The following is a description of a gene set: Human Gene Set: WCAANNNYCAG_UNKNOWN from publication Xie X, Lu J, Kulbokas EJ, Golub TR, Mootha V, Lindblad-Toh K, Lander ES, Kellis M (PMID 15735639) species: Homo sapiens Genes having at least one occurrence of the highly conserved motif M152 WCAANNNYCAG in the regions spanning 4 kb centered on their transcription starting sites. The motif does not match any known transcription factor binding site. Comprehensive identification of all functional elements encoded in the human genome is a fundamental need in biomedical research. Here, we present a comparative analysis of the human, mouse, rat and dog genomes to create a systematic catalogue of common regulatory motifs in promoters and 3' untranslated regions (3' UTRs). The promoter analysis yields 174 candidate motifs, including most previously known transcription-factor binding sites and 105 new motifs. The 3'-UTR analysis yields 106 motifs likely to be involved in post-transcriptional regulation. Nearly one-half are associated with microRNAs (miRNAs), leading to the discovery of many new miRNA genes and their likely target genes. Our results suggest that previous estimates of the number of human miRNA genes were low, and that miRNAs regulate at least 20% of human genes. The overall results provide a systematic view of gene regulation in the human, which will be refined as additional mammalian genomes become available., and this is the list of marker genes: CACNB3 (NCBI Gene Id 784), SCNM1, STARD13, AP1G2, GDNF, CERT1, SLC25A28, SMAD5, ATXN7L2, HCFC1R1, VPS45, SP8, SALL1, CD244, SERTAD3, FOXM1, FOXP2, GBX2, CHTOP, PANK3, ELP6 (elongator acetyltransferase complex subunit 6), FBXO36, TMEM150A, CNOT4, CREB1, SCN8A, EPS8L2, NRAS, DMD, BMP4, CNGA1 (NCBI Gene Id 1259), TRMT10B, RAB3GAP2, TAFAZZIN, IFTAP, MACROD1, OTUD7B, RDH14, NFIX, LRRC74A, FGFR3, SLC38A9, SOBP, PHF12, LMAN2, ZNF32, WNT9A, AGXT2, PRRT2, ARF6, TRIM23, ZNF644, PCDH10, HAUS1, NUMA1, POLK, SUFU, FGFR1, PLCG1, NSG2 (neuronal vesicle trafficking associated 2), BTRC, CPNE9, KCNJ5, APH1A (aph-1 homolog A, gamma-secretase subunit), MIR22HG, NEUROD6, DNAJC18, MYH6, CHM, TTR, LMX1B, SMUG1, TUG1 (NCBI Gene Id 55000), LRTOMT, DCAKD, USH1C, JUP, CDK9, MISP, DOCK11, MYLIP, POU4F3, ANGPT4, AAK1, PA2G4 (proliferation-associated 2G4), CLN5, CEP97, INTS9, ZNF513, MAP3K10, OTX1, LRRN2, ARHGEF2, UBL3, HMBOX1, MRPL24, SERBP1, ATP5PO, KLK1, PGPEP1 (NCBI Gene Id 83542), PHLPP1, HCLS1, SLC39A5, DCUN1D4, WDR81, ZNF691, ACTR1A, PURA, NCAM1, C2CD2L, YWHAG, BUB1B, ZNF180, HECTD2, SMARCAL1, RALBP1, PRDM1, EPB41L2, CNTFR, NPRL2, SMCR8, PPP2R2B (protein phosphatase 2 regulatory subunit Bbeta), HOXD10, CA11, PSMD4, GRWD1, THPO, NFXL1, TRMT10A, LRP1, RHNO1, ZBTB20, SPATC1, MAVS, SLC4A2, EHBP1, CIAO1, BMF, QTRT2, BCKDK, RAB30, PTCHD4, ZBED10P, CCDC25, PHTF2 (NCBI Gene Id 57832), PCDH8, ZC4H2, BIN3, DNAJC5B, INVS (inversin), OSCAR, NPHP4, KMT2D, LYSMD1, CDKL5, NDUFA3, ZBTB26, HEXIM2, RPP40, RDH10, NMT1, PROS1, DNAJA2, JARID2, TBX6, SLC44A1, PIGV, TCEA2, SYT3, ZBTB9, PRCC, PPHLN1, HSCB, RELCH, SOX2, SRGN, WBP2, TOP3A, ERBB3, GTPBP8, TAB2, BCL2L1, MVB12A, TMEM102, NKX2-3, ALKBH4, TMEM115, SCUBE3, R3HCC1L, CBLL1, CPNE1, THOC6, PABIR1, OTUB1, CNGA3, LRWD1, TCEAL9, CYB561D2, TRAPPC13, SYNCRIP, MSL3, SV2A (NCBI Gene Id 9900), HS3ST5, BCOR, VILL, RNF183, TMEM88, SLC31A2, TMEM127, UBXN8, SOX1, CDK5, FGF10, ARTN, SLC6A9, CCDC191, KLF5, ZNF485, POLR1G, SPEF1, EGR3, ZNF8, NCLN, RBM41, MAPK10, NUTF2, FETUB, ARID5A, ZNF274, YBX2, HNRNPM, SYT17, STAG2 (NCBI Gene Id 10735), ENPP6, PDE6D, RPL7, TNNI1, SCN2B, SCAF11, TNNC1, LARS1, ORMDL3, PLEKHB1, MSI2, DPF3, ZCRB1, RNASEH2A, BCL6, NEXN (nexilin F-actin binding protein), BANP, DYNC1LI1, KLF7, ATP5F1A, ENKD1